Given this list of marker genes Mapk14, Zfp936 (NCBI Gene Id 668620), Thsd7b, Il20, Cmah, Zfp971, Rev3l, Rora, Shisa9, Cyp11a1, Zfand3, Chrdl1, Pcdhb3, Cops2, 2210418O10Rik, Steap2, Zfp935, Gas2l3, Nabp1, Zfp967, Mxd1, Kcng3, Krtap4-13, Nlrp10, Gm10413, Prrc2c, Tgfbr2, Spin1, Shank2, Cntn4, Kdm4c, Trip11, Ywhab, Slitrk2, Strbp, Zfp516, Bclaf1, Hnrnph1, P4hb, Snx2, Dpp10, Dcaf5, Zhx3, Txnrd1, Dach2, Vdac3, Gm14322, Zfp26 (zinc finger protein 26), Vps50, Cdh8, Ogfrl1, Zeb1, Alox12, Celf1, Zfp1009, Rab30, Inpp5a, Nebl, Kctd13, Zfp966, Dpy19l2, Cd24a, Zfp970, Fbxo43, Shtn1, Tfap2a, Slc25a24 (NCBI Gene Id 69910), Armt1, Ypel2, C1qtnf9, Hnrnpf, Foxg1, Psap, Sppl3, Rhov, Zbtb10, Neil3, Kcnq2, Kcnh5, Api5, Il5ra, Nit1, Ppp1r14c, Far1, Elk3, Trmt10c, Cd53 (CD53 antigen), Atp1b1, Prkg1, Kcnab1, Piezo2, Samd8, Chd9, C330018D20Rik, Pla2g4e, Mtdh, Adamts19, Gm14296, Nxph1 (neurexophilin 1), Dbpht2, Foxp3, Pogz, Krtap4-21, Mef2a, Bcl11a, Atxn10, Zeb2 (zinc finger E-box binding homeobox 2), Rps24, Cstf2, here is a description of the gene set: species: Mus musculus from publication Chen Y, Wang X (PMID 31504780) Mouse Gene Set: MIR_124_5P Genes predicted to be targets of miRBase v22 microRNA mmu_miR_124_5p in miRDB v6.0 with MirTarget v4 prediction scores > 80 (high confidence targets).